The following is a description of a gene set: studied in species Mus musculus electronically inferred by orthology from the curated human pathway part of: Response to metal ions Reactome Pathway: Metallothioneins bind metals This event has been computationally inferred from an event that has been demonstrated in another species.<p>The inference is based on the homology mapping from PANTHER. Briefly, reactions for which all involved PhysicalEntities (in input, output and catalyst) have a mapped orthologue/paralogue (for complexes at least 75% of components must have a mapping) are inferred to the other species., and this is the list of marker genes: Mt3, Mt2